Given this list of marker genes Osr1, Pdgfb, Notch1, Foxc2, Gpr4, Cd34, Acta2, here is a description of the gene set: Mouse Gene Set: GOBP_MESANGIAL_CELL_DIFFERENTIATION species: Mus musculus The process in which relatively unspecialized cells acquire specialized structural and/or functional features that characterize the mesangial cells of the kidney as it progresses from its formation to the mature state.